The following is a description of a gene set: from publication Konuma T, Nakamura S, Miyagi S, Negishi M, Chiba T, Oguro H, Yuan J, Mochizuki-Kashio M, Ichikawa H, Miyoshi H, Vidal M, Iwama A (PMID 21540074) Each fraction of mouse hematopoietic cells was purified by cell sorting from bone marrow of 8-week-old C57BL/6 mice, and its gene expression was analyzed. Genes up-regulated in comparison of LSK versus erythroblasts. Human Gene Set: GSE27786_LSK_VS_ERYTHROBLAST_UP studied in species Homo sapiens, and this is the list of marker genes: ZC2HC1A, ZBTB24, FUBP3, NOL8, MYCBP2, COG3, CNOT2, FUCA2, C12orf75, MFSD14A, IKBKB, SCO1, CRELD2, NDUFV2, POLD1, DUSP16, DCAF15, LMF1 (NCBI Gene Id 650392), EFR3A, WDR77, HEG1, HMG20A, PDLIM1, ZNF623, CASP8 (caspase 8), TKT, NDUFS3, ST14, PFAS, C6orf136, CEMIP2, ATG4C, DPP3, TTI1, TM9SF4, SCFD2, ZNF560, SNX9, STAT5A, RAP2B, PWWP3B, ANKRD13D, DBI, GBP7, RPS6KA6, NDUFS4, SSR2, DCTN6 (dynactin subunit 6), TRAF3IP1, IDS, SFXN2, VHL, EMG1, RMND5B, TUFM, ADGRE5, PPHLN1, GNPDA2, PLBD2, GPATCH2, SIGMAR1, BTBD2, MRPS25, WASHC4, SCARB1, NFIC, MRPL27, JDP2, ZNF260, RNF103, BOLA2, GATM, SF3A3, ARB2A, STX16, MATN2, IL18RAP, NAXE, BLCAP, CHM (CHM Rab escort protein), RUVBL1, SLFN13, CYB561A3, MGA, SESN3, LAIR1, BCKDK, TSHZ1, URGCP, ATP6V1H, LSP1 (NCBI Gene Id 4046), BTBD1, DLEU7, OTULIN, TNKS2, GUF1, RAPGEF1, CHD3, STYX, PIBF1, PDXP, RBL2, COPS3, PIK3AP1, TNFRSF18, PRKCD, KCNQ1OT1, TSKS, SLF2, SDHA, BRD3, MTHFD1, EI24, ARSK, EXOC1 (NCBI Gene Id 55763), GOT2, ATP8B2, ZNF32, CAD, EBP, ZNF518A (zinc finger protein 518A), PPM1K, DPAGT1, FIBP (FGF1 intracellular binding protein), CDK9, ARHGEF3, TMEM229B, NAB1, BET1, ZDHHC4, RASA4, MEX3B, AK4 (adenylate kinase 4), CHST14, VILL, C8orf82, ZNRD2, MSN, NUDT6, KIF1C, FRRS1, SIK3, CDC14A, APPBP2, CCDC71, RASGRP2, MYADM, IKBKE, NT5C3B, POMP, RAD1, GLRX3, SLC25A36, PHKA2, IDH3A, IFT74, PRDM2, SLC9A9, PGPEP1, DYNLRB1, FBXO6, RRP36, ERCC5, ZC3H7A, RPS7 (NCBI Gene Id 6201), IL15, MECR, TAF1B, HIKESHI (heat shock protein nuclear import factor hikeshi), ANTKMT, SPP1, TRDMT1, DUS3L, MYCT1, FLYWCH1, STIM2, MTF2, DHRS7, CORO1C, PHF14, POMGNT1, FAM53A, SEL1L, IARS2, UXS1, PDE7A, ASNSD1, KDM1A, VPS33A, ARFGAP2, DLG3, NPHP1, PACRGL, WRNIP1, WDR19, TEFM, SUPT5H, RHEBL1, IMMP2L, MTM1